The following is a description of a gene set: Binding to a lipopolysaccharide. species: Homo sapiens Human Gene Set: GOMF_LIPOPOLYSACCHARIDE_BINDING, and this is the list of marker genes: SPON2, BPI, BPIFA2 (NCBI Gene Id 140683), NLRP6, TREM2, DEFB136, RNASE3, PSMA1, LTF, PSMB4, GBP1, NR4A1, DROSHA, SCARB1, SELP, DEFB114, NINJ1, CD14, TLR2, HSPD1, DEFB106A, RNASE7, DEFB118, DMBT1, HMGB1 (NCBI Gene Id 3146), P2RX7, BPIFC, TLR4 (NCBI Gene Id 7099), DEFB106B, CD6, CASP4, DEFB119, ADGRB1, CAMP, F2, LBP, PTAFR, LY96, RNASE2, ZRANB2, H2BC11, TRIL